Given this list of marker genes HACD1, NDUFS8, SCN4A, FGF13, CC2D2A, SCN5A, PLA2G6, FBP1, ACADSB, NACC1, here is a description of the gene set: Recurrent episodes of apnea occurring during infancy. studied in species Homo sapiens Apneic episodes in infancy Human Gene Set: HP_APNEIC_EPISODES_IN_INFANCY